The following is a description of a gene set: Mouse Gene Set: GOBP_REGULATION_OF_PROTEIN_CATABOLIC_PROCESS Any process that modulates the frequency, rate or extent of the chemical reactions and pathways resulting in the breakdown of a protein by the destruction of the native, active configuration, with or without the hydrolysis of peptide bonds. studied in species Mus musculus, and this is the list of marker genes: Smad4, Cop1, Styx-ps, Socs4, Ubqln1, Sco1, Gja1, Mdm4, Pacsin3, Ifng, Fbxo43, Adam9, Gba1, Desi1, Pkd1, Amer1, Ins1 (insulin I), Ccar2, Usp5, Tmf1, F8a, Sirt2, Sorl1, Stub1, Rybp-ps, Tnf, Eif2ak3, Timp4, Usp9x, Rad23a, Agap2, Trim39, Sh3rf3, Rnft2, Rbx1-ps, Usp8, Psme3ip1, Prkn, Dtl, Gpld1 (glycosylphosphatidylinositol specific phospholipase D1), Ubxn2a, Usp38, Rnf40, Timp1, Trim30a, Phb1 (NCBI Gene Id 18673, prohibitin 1), Grin2a, Adgrb1, Ppp2ca, Psen2, Mad2l2, Fbxo11, Cul4b, Bag6, Mgat3, Nedd4l (NCBI Gene Id 83814), Axin2, Foxo1, Timp3 (tissue inhibitor of metalloproteinase 3), Paqr3, Mapk8, Bag2, Pin1rt1, Fbxw8, Zer1, Serpine2, Zyg11b, Pttg1ip, Psmd3, Ddrgk1, Hsp90aa1, Oaz3, Abca2, Nsf, Hspbp1, Zfand2a, Crebrf, Egfr, Bmal1, Msn, Egln2, Lamp3, Rhbdd1, Snx12, Csnk2a2, Ubr3, Wnt5a, Foxf2, Asb11, Ndufa13, Mapk9, Sgta (small glutamine-rich tetratricopeptide repeat (TPR)-containing, alpha), Ogt, Mycbp2, Sirt6, Wnt10b, Vip, Plk2, Sh3rf2, Aurka, Faf1, Usp25, N4bp1 (NCBI Gene Id 97462), Wdr91, Gabarapl2, Usp19, Nkd1, Psmd1, Dnajb2, Gga3, Eif2a, Cul4a, Atp13a2, Flna, Tmem67, Det1, Nudt15, Sgsm3, Snx33, Csnk1a1, Azin1 (antizyme inhibitor 1), Wac, Snf8, Ecscr, Psmd2, Plk1, Dab2, Alad, Araf, Hamp, Prkaca, Cst3, Nop53, Fbxo22, Cdk5rap3, Styx, Serpinb1a, Usp13, Adam8, Ndfip1, Pias1, Socs5, App, Sumo2, Grin2c, Rack1, Pabpn1l, Dnaaf4, Psme3, Snx1, Nell1 (NEL-like 1), Csnk1e, Ubqln2, Serpinb1b, Clec16a, Azin2, Hspa1a, Vgll4, Rdx, Furin, Pabir1, Tnfaip3, Phf20l1, Xpo1, Ubxn1, Lpcat1, Tmem9, Bbs7, Sumo1, Gna12, Commd1, Mylip, Rnf180, Atg7, Sec22b, Klhl40, Pbk, Fmr1, Cenatac, Sox17, Clu, Tspan5, Psme2 (NCBI Gene Id 19188), Psmd10, Rilp, Ophn1, Rybp, Nedd4 (neural precursor cell expressed, developmentally down-regulated 4), Epm2a, Nupr1, Gsk3a, Rgp1, Caml, Kcne2, Trim32, Hmgcr, Il1b, Nqo1, Map1a, Dcaf1, E330034G19Rik, Senp1, Marchf2, Vps11, Nfe2l1, Sh3d19, Rnft1, Prickle1 (prickle planar cell polarity protein 1), Akt1, Rab7, Sf3b3, Zdhhc2, Lrp1, Apc, Usp7, Plk3, Rgma, Mfsd8, Marchf7, Snx9, Trib2, Gfap, Ubb, Tnfsf12, Pithd1, Hspa1b, Oaz1, Gpx1, Psen1, Csnk1d, Fyn, Tnfrsf1b, Il10, Hfe, Laptm4b, Ppp2r3a, Timp2, Smad3, Dysf, Zfp418, Hsp90ab1, Dedd, Apoe, Asb5, Fzr1, Tmx1, Glmn, Vcp, Atraid, Eif3h, Irak3, Tspan15, Cyp51, Ldc1, Park7, Xbp1, Ddb1 (damage specific DNA binding protein 1), Lrig2, Dvl1, Anxa2, Gipc1, Rpl11, Mad2l1, Prkcg, Trf, Oaz2, Adra2a, Cbfa2t3, Fbxl5, Tmtc3, Rnf19a, Cdh1, Psme1, Nrg1, Fbxw7, Usp26, Gpc3, Rbx1, Bag5, Tiparp, Chfr, Cdc20b, Chek2, Ern1, Dact1, C4bp, Ubqln4, Shh, Dlgap1, Cdc20, Trib1, Ctsa, Cav1, Pcsk9, Rhbdd3, Ttc36, Samd9l, Ins2, Tmem259, Tlk2, Rela (v-rel reticuloendotheliosis viral oncogene homolog A (avian)), Ptpn3, Gabarap, Sirt1, Fam83d, Nos2, Vps35, Rchy1, Csnk2a1, Atg4b (autophagy related 4B, cysteine peptidase), Bcap31, Axin1, Rad23b, Fhit, Pin1, Tspan17, Cblb, Cdkn1b, Odc1, Ric1, Smarcc1, Mdm2, Rnf185, Aqp11, Herpud1 (NCBI Gene Id 64209), Trib3, Chmp6, Csnk2b, Osbpl7, Psmd14, Gclc, Ier3, Mapk15, Mtm1, Rhbdf1, Stx5a, Gsk3b, Taf9, Ufl1, Il33, Fbxo2, Usp14, Nub1, Psmf1, Ldlr, Btrc, Vps28, Sox9, Rnf41, Lrrk2, Nkd2, Snx3, Cd81, Nrdc, Atxn3, Tmem132a, Itch, Uchl5, Fmn2, Dda1, Asb9, Ube2k, Ezr, Dab2ip, Trem2, Trim40, Sh3rf1, Wfs1, Fbxl20, Zp3r, Gga1 (NCBI Gene Id 73931), Svip, Snca (synuclein, alpha), Ube2v2 (ubiquitin-conjugating enzyme E2 variant 2)